Given this list of marker genes Ocln, Tjp3, Tjp2 (tight junction protein 2), Angpt1, Tjp1, here is a description of the gene set: studied in species Mus musculus Mouse Gene Set: GOBP_POSITIVE_REGULATION_OF_BLOOD_BRAIN_BARRIER_PERMEABILITY Any process that increases blood-brain barrier permeability, the quality of the blood-brain barrier that allows for a controlled passage of substances (e.g. macromolecules, small molecules, ions) into and out of the brain.